Given this list of marker genes RPL27, SON, TP63, RPS28, NEK1, KCNK9, GRHL3, RPS24 (ribosomal protein S24), DDX59, SF3B4, GNB2, RPL35, RPL9, H4C5, COL2A1, RPS19, BUB1, RPS15A, SMARCD1, HEATR3, STAG2, RPL35A, SCNM1, ZSWIM6, NXN, FKBP14, GATA1, RPS27 (NCBI Gene Id 6232), DYRK1A (dual specificity tyrosine phosphorylation regulated kinase 1A), RPL15, IPO8, RPL31, POLR3A, RPS20, RPL8, RPL18, RPL5, MSX2, TCOF1, ZEB2, UBB, RPS26, RPL26, TBX5 (NCBI Gene Id 6910), DVL1, SNRPB, RPS17, RPS7, TAF4, ZPR1, RPS29, MED12, STAC3, TSR2 (TSR2 ribosome maturation factor), ADA2, NONO, RPL11 (NCBI Gene Id 6135), TGFB3, RPS10, SLC25A19, here is a description of the gene set: species: Homo sapiens Human Gene Set: HP_CLEFT_SOFT_PALATE Cleft of the soft palate (also known as the velum, or muscular palate) as a result of a developmental defect occurring between the 7th and 12th week of pregnancy. Cleft soft palate can cause functional abnormalities of the Eustachian tube with resulting middle ear anomalies and hearing difficulties, as well as speech problems associated with hypernasal speech due to velopharyngeal insufficiency. Cleft soft palate